Given this list of marker genes Pdxdc1, Alkbh1, Ufm1, Ngfr, Tubg2, Ptf1a, Ube2h, Ighmbp2, here is a description of the gene set: Mouse Gene Set: MIR_592_3P Genes predicted to be targets of miRBase v22 microRNA mmu_miR_592_3p in miRDB v6.0 with MirTarget v4 prediction scores > 80 (high confidence targets). studied in species Mus musculus from publication Chen Y, Wang X (PMID 31504780)